The following is a description of a gene set: studied in species Mus musculus Mouse Gene Set: GOCC_ADHERENS_JUNCTION A cell-cell junction composed of the epithelial cadherin-catenin complex. The epithelial cadherins, or E-cadherins, of each interacting cell extend through the plasma membrane into the extracellular space and bind to each other. The E-cadherins bind to catenins on the cytoplasmic side of the membrane, where the E-cadherin-catenin complex binds to cytoskeletal components and regulatory and signaling molecules., and this is the list of marker genes: Ccdc85b, Actb, Apc, Ahi1, Ajap1, Tspan33, Igsf21, Pgm5, Mtss1, Ppp1r9b, Pdlim3, Notch1, Dag1, Oxtr, Ceacam2, Kifc3, Synm, Afdn, Fmn1, Cdh19, Cdh8, Lyn, Ctnna3, Itgb1, Tmem204, Cdhr18, Cdh15, Rdx, Cdh22, Cdh17, Ctnnb1, Ceacam1, Cxadr, Ldb3, Pard3, Tmigd1, Fermt2, Pvr, Plekha7, Tmem47, Ajuba, Lmo7, Lin7c, Ndrg1, Ehd4 (NCBI Gene Id 99247), Shroom3, Limd1, Epha4, Dlg5, Cdh20, Itga6, Frmd5, Vinac1, Cdh1, Sh3bp1, Tbcd, Pdlim2, Cdh7, Pkp4, Nphp1, Cdh26, Niban2, Klhl24, Dll1, Sdcbp, Pdzd11, Cyth3, Wtip (WT1 interacting protein), Mpp7, Cdc42ep4, Pip5k1c, Shroom1, Nf2, Alox8, Cdh10, Cdh13, Lin7b, Lrrc7, Myo1e, Zyx, Nectin2, Scrib, Pard3b, Epha5, Pdlim4, Cdh6, Ddx6 (NCBI Gene Id 78705), Vegfa, Arvcf (NCBI Gene Id 11877), Cdca3, Cyth1, Cdh3, Rnd1, Ctnna2, Efnb2, Dlg1, Pdlim1, Abi2, Pals1, Flot1, Esam, Dsg3, Cdh5, Lama3 (NCBI Gene Id 16774), Ccdc85c, Nectin3, Hmcn1, Nexn, Vezt (vezatin, adherens junctions transmembrane protein), Camsap3, Jup, Cdh12, Epb41l5, Cdh4, Tln1, Smad7, Arhgap24, Ctnna1, Ajm1, Frmd4b, Dsc2, Trpv4, Pacsin2, Cdh2, Magi1, Cd99l2, Ptprm, Prickle4, Xirp1, Pkp1 (plakophilin 1), Pdlim5, Crb1, Flot2, Shroom4, Mpp4, Efna5, Nectin1, Cyth2, Cdh9, Pof1b, Sorbs1, Ccdc85a, Dsp, Adam10, Frs2, Nectin4, Myh9, Vcl, Bmpr2, Mpp3, Msn, Adam15, Pkp3, Fat2, Tnks1bp1, Wnk3, Ctnnd1, Frmd4a, Tjp1, Ezr, Tnk2, Ssx2ip, Fer, Pkp2, Jag1, Lin7a, Pdlim7, Tgm1 (NCBI Gene Id 69510), Cdh18, Jcad, Shroom2, Cdh11, Micall1, Tjp2, Snap23 (NCBI Gene Id 98773, synaptosomal-associated protein 23), Add1, Ppp1ca, Cdh24, Ctnnd2, Keap1